The following is a description of a gene set: Binding to a glutamate receptor. Mouse Gene Set: GOMF_GLUTAMATE_RECEPTOR_BINDING species: Mus musculus, and this is the list of marker genes: Ube2i (NCBI Gene Id 76085), Myl12a, Grin1, Pias3, Grin2b, Prnp, Fyn (Fyn proto-oncogene), Shank1, Plcg1, Grip1, Calm2, Snx27, Pten, Il1r1, Esr1, Grin2a, Dnm3, Akap5, Eml2, Cabp1, Oxtr, Fus (fused in sarcoma), Rab4a, Map1a, mt-Nd2, Gnas, Nsf, Grip2 (glutamate receptor interacting protein 2), Dlg4, Neto1, Ptk2b (PTK2 protein tyrosine kinase 2 beta), Shank2, Homer2, Pick1, Dlg3, Nsg1, Nedd4, Neto2, Drd2, Dlg2, Homer1, Homer3, Shisa7, Gria2, Rasgrf1 (RAS protein-specific guanine nucleotide-releasing factor 1), Camk2a, Flot1, Shisa6, Gria1, Sdcbp, Ophn1, Cdk5r1, Sqstm1, Syndig1, Adrb2, Atp2b2, Calm3, Ptpn4, Agap2, Canx, Exoc4, Phaf1, Myo5b, Gripap1 (NCBI Gene Id 54645), Nherf1, Cacng3, Necab2, Cacng8, Shank3 (NCBI Gene Id 58234), Gsk3b, Igsf11, Flot2, Calm1, Cacng4, Arpc2, Dlg1, Adora2a, Cacng2, Ctnnb1, Rapsn